The following is a description of a gene set: Monocyte-derived dendritic cells (DC) and macrophages (MΦ) generated in vitro from the same individual blood donors were exposed to five different pathogens, and gene expression profiles were assessed by microarray analysis. Responses to Mycobacterium tuberculosis and to phylogenetically distinct protozoan (Leishmania major, L. donovani, Toxoplasma gondii) and helminth (Brugia malayi) parasites were examined, each of which produces chronic infections in humans yet vary considerably in the nature of the immune responses they trigger. species: Homo sapiens Human Gene Set: GSE360_L_MAJOR_VS_B_MALAYI_HIGH_DOSE_MAC_DN Genes down-regulated in comparison of macrophages exposed to L. major versus macrophages exposed to 50 worms/well B. malayi. from publication Chaussabel D, Semnani RT, McDowell MA, Sacks D, Sher A, Nutman TB (PMID 12663451), and this is the list of marker genes: CPVL, CHAF1A, SF3B3, MED8, APOBEC3B, FCGRT, TARBP2 (NCBI Gene Id 6895), COX7B, CD4, NISCH, MYT1L, PTK2B, FUT1, LRRC37A2, ARHGEF1, HEXA, SREBF2, PSMD8, PLS3, DHCR7, SNX15, TOX, HSD11B2, CCNB1, APLP1, PRCP, YES1, ALDOC, DOK5, INTS9, AMHR2, ECHS1 (enoyl-CoA hydratase, short chain 1), RNASE1, RPP30, ITGAL, CAPZB, HLA-DRB6, RHOA, GAPVD1, ARR3, TAOK3, KCNJ1, LSM4 (NCBI Gene Id 25804), CRYAA, MFN2, GPT, DGAT1, PCCA, CHMP2A, PARP3 (NCBI Gene Id 25908), ATRN, AGTPBP1, OVOL3, GOLGA3, CEBPA, TRAPPC6A, ACVR1B, IL18, EXOSC7, CDC25B, IRF5, UBXN1, PCMT1, DDB2, PTPN18, CKAP5, NDUFV1, PSEN2, RAE1, TRRAP (transformation/transcription domain associated protein), TGFBR2, PRDX2, NDUFB8, MEA1, NMU, PTPRCAP, ACAA1, INPP4B, MDN1, IMPDH1, SNAPC5, RPL10A, RALGAPB, GLB1, IDH3B, NDUFS7, SHMT2, STIP1, RPL13P5, TAL1, ANGPTL7, LAMB2, TGIF2, COLEC10, NIPSNAP1, EIF3K, SETD1B, SMPD1, SF3B2, DLEC1 (NCBI Gene Id 9940), TAF10, AHSG, ZNF629, AHCY, AP2S1, NFE2L3, TLE2, CYC1, INPP5D, SKIC2, AFG3L2, APRT, CKS1B, EGR4, DZIP3, MRPS27, EFNB3, CFD, NKX2-8 (NK2 homeobox 8), TSN, MIEF1, PCK2, MARS1, PRRC2B, ABCB7, SLC43A1 (NCBI Gene Id 8501), NEU1, PATZ1, ITSN1, ATP6V0D1, UNC119, ATP5MC1, SNRPE, CDA, PSME4, SKAP2, ZBTB20, KCNJ9, SPC25 (SPC25 component of NDC80 kinetochore complex), PRRC2A, ETFDH, NDUFB7, PYGM, MUC6, STAB1, CARS1, ECI1, GPR15, CD22, UTP18, GATM, TRAF3, ABCA2, CD27, IQSEC2 (NCBI Gene Id 4382, IQ motif and Sec7 domain ArfGEF 2), RSL1D1, TNN, PLCG2, PRODH, DEDD, GLG1, FADS2, PBX2 (NCBI Gene Id 5089), PLK2, PLA2G2A, HLA-DMB, UGT8, FARSA, ESYT1, ZNF20, UNC93A, VARS1, RIN2, CEACAM7, KAT6A, PARD6A, MYBL2, LMO2, BANF1 (barrier to autointegration nuclear assembly factor 1), OR7A5 (NCBI Gene Id 55551), CYBB, IMPDH2, CALM2, RASSF1, BTN3A2, PRKCA, PLXND1, PRKAG1, GATD3, PI4K2A, TRAPPC12, PRKCH, NDUFB6, ANAPC10, RNF114, TRIM44 (NCBI Gene Id 54765), ZNF142, DNPH1, DHX16